The following is a description of a gene set: Mitochondrial respiratory chain defects Human Gene Set: HP_MITOCHONDRIAL_RESPIRATORY_CHAIN_DEFECTS studied in species Homo sapiens, and this is the list of marker genes: MT-ND4L, MT-ND2, DNAJC30, MT-CO1, SLC3A1, MT-CO3, NDUFS2, PNPT1, MT-ND4, MT-ND5, CAMKMT, PPM1B, MT-ND6, PREPL, CYP27A1, MT-ND1, MT-CYB, TRMU, MT-ATP6